Given this list of marker genes Grip2, Epb41l1, Gripap1, Snap23, Mapk10, Sacm1l, Grin1, Adam22, Lrrc7, Erbb2, Grin2a, Dlg4, Stau2, Baiap2, Dlg2, Magi2, Lgi1, Prkcz, Kif5b, Reln, Shank1, Nlgn1 (NCBI Gene Id 99949), Rab8a, Gsk3b, Traf6, Nlgn2, Stx3, Iqsec2, Cplx1, Cacng3, Cacng7, Vwc2, Ghsr, Nptxr, Nrxn2, Zdhhc2, Nptx2, Neto2, Klc1, Dlg1, Nphs1, Stx1b, Map1a, Nrxn1, Nrxn3, Tmem108, Bsn, Zdhhc12 (NCBI Gene Id 66220), Mylk, Kif5a, Scrib, Dok7, Cnih3, Dlg3, Slitrk3, Mapt, Musk, Lhfpl4, Gphn, Rapgef4, C1ql3, Git1, Ogt, Rab27b, Vps26b (VPS26 retromer complex component B), Gabarap, Cacng2, Nbea, Stau1, Gpc6, Zdhhc15, Gpc4, Nlgn3, Grin2c, Kif2c, Mpp4, Kalrn, Vamp2, Gpsm2, Grip1, Nsg1, Rap1a (NCBI Gene Id 99734), Lrrtm1, Clstn1, Agrn, Kif5c, C1ql2, Nptx1, Mapk8ip3, Dag1, Stx4a, Cacna2d2 (calcium channel, voltage-dependent, alpha 2/delta subunit 2), Snap47, Adam10, Map2k1, Abhd17b, Neto1, Vps35, Rapsn, Olfm2, Asic2, Dlgap1, Pclo, Hras, Clstn3, Rab11a, Tnik, Erbb4, Cdk5, Arhgap44, Homer1, Hspb1, Camk2a, here is a description of the gene set: Any process in which a protein is transported to, and/or maintained at the synapse, the junction between a nerve fiber of one neuron and another neuron or muscle fiber or glial cell. Mouse Gene Set: GOBP_PROTEIN_LOCALIZATION_TO_SYNAPSE studied in species Mus musculus